The following is a description of a gene set: Pathway Definition from KEGG: (RBCK1+RNF31+SHARPIN) -> (RIPK1,IKBKG,TNFRSF1A) studied in species Homo sapiens Regulation of TNF-NFKB signaling pathway, LUBAC-mediated linear ubiquitination. Pathway ID: N01545. Pathway type: Reference. Pathway class: nt06516 TNF signaling. Human Gene Set: KEGG_MEDICUS_REFERENCE_REGULATION_OF_TNF_NFKB_SIGNALING_PATHWAY_LUBAC_MEDIATED_LINEAR_UBIQUITINATION, and this is the list of marker genes: IKBKG, RIPK1, RBCK1, RNF31, TNFRSF1A, SHARPIN